The following is a description of a gene set: alpha-linolenic (omega3) and linoleic (omega6) acid metabolism studied in species Homo sapiens Human Gene Set: REACTOME_ALPHA_LINOLENIC_OMEGA3_AND_LINOLEIC_OMEGA6_ACID_METABOLISM, and this is the list of marker genes: ABCD1, HSD17B4, ELOVL2, ACOT8, FADS2, FADS1, SCP2 (NCBI Gene Id 6342), ACAA1, ELOVL1, ELOVL5, ACOX1, ACSL1, ELOVL3